Given this list of marker genes PTK2B, INVS (NCBI Gene Id 8014), MAPK1, NPHP4, FLNC, FLNA, MAPK3, NPHP1, BCAR1, FLNB, RPGRIP1L, here is a description of the gene set: NPHP1 deletion syndrome species: Homo sapiens Human Gene Set: WP_NPHP1_DELETION_SYNDROME